The following is a description of a gene set: from publication Chen Y, Wang X (PMID 31504780) species: Homo sapiens Human Gene Set: MIR3689A_5P_MIR3689B_5P_MIR3689E_MIR3689F Genes predicted to be targets of miRBase v22 microRNA hsa-miR-3689a-5p, hsa-miR-3689b-5p, hsa-miR-3689e, hsa-miR-3689f in miRDB v6.0 with MirTarget v4 prediction scores > 80 (high confidence targets)., and this is the list of marker genes: SIGLEC5, SLC6A8, TSHR, ROCK1, RAB11A, DTWD1 (DTW domain containing 1), HPS3, FAM117B, RSU1, TRHDE, HCN1, MPRIP, RNF168, ASPH, NLGN1, MED13, TSHZ2, COL17A1, ZBTB20 (zinc finger and BTB domain containing 20), CTCFL, RGL2, SKAP2, FZD2, PHTF2, NLGN4Y, AOX1, PPFIA1, FOXL2NB, HNRNPA0, ARPP21, MYO7A, HSPA13 (heat shock protein family A (Hsp70) member 13), CELF2, ITM2B, NANOS1, TMEFF2, CYB5R4, SFXN1, PTCHD4, DIP2A, CYP3A4, ARNT, TBC1D2B, AQP4, RPAIN, RASGRP3, KLF7, GLRB, DNAJC25, TMEM265, PSD3, BTBD8, PRR27, GRM1, UNC13C, PRTG, PPP1R21, GMNC, NDUFAF5, COCH, A1CF, TLR7, PDE4D, RBM41, EBAG9, ADGRL4, GINS3, SLC39A7, BNIP3, AOC2, ARSJ, SSBP2, TENT5D, SLC30A4, SMAD9, SP4, FGF14, TRIM5, TMBIM1, GPATCH8, LRP6, PTGR3, ZNF107, OPCML, PHF20L1 (PHD finger protein 20 like 1), AZIN1, TWF1, ADGRA1, PCDH11X, ANKRD50 (NCBI Gene Id 57182), HSF5, ADAM10, PIK3CG, CDH19, FAM76A, HYDIN, GDAP1, EMC2, ATL1, RTL3, EFHC2, DNAI7, UBE2V2 (NCBI Gene Id 7336), CERT1, TCEAL8, SYT1, MTMR12, ZBTB14, CDC14A, CCNE2, SPRED1, SHANK2, NETO1, GLRA2, B3GNT9, CDH9, TET3, NEXMIF, EXOC5, NCKAP5, PPM1B, HYLS1, ZNF529, REPS2, MYH11, ZNF783 (zinc finger protein 783), PRKACB